Given this list of marker genes Polr3g, Polr2k, Gtf3c3, Gtf3c2, Polr3h, Polr2e (polymerase (RNA) II (DNA directed) polypeptide E), Polr3c, Polr1c, Gtf3c1, Crcp, Gtf3c5, Tbp, Polr2f, Polr3d, Gtf3c6, Polr3e, Polr2l, Bdp1 (NCBI Gene Id 544971), here is a description of the gene set: electronically inferred by orthology from the curated human pathway Reactome Pathway: RNA Polymerase III Transcription Initiation From Type 1 Promoter part of: RNA Polymerase III Transcription Initiation This event has been computationally inferred from an event that has been demonstrated in another species.<p>The inference is based on the homology mapping from PANTHER. Briefly, reactions for which all involved PhysicalEntities (in input, output and catalyst) have a mapped orthologue/paralogue (for complexes at least 75% of components must have a mapping) are inferred to the other species. studied in species Mus musculus